Given this list of marker genes TEAD2, ONECUT1, HSF4, PAX1, HOXC6, ZBTB24, RAX2, ZNF611, PRMT5, MSX2, KDM6A, PURG, CENPC, MCM5, ZNF575, ZNF649, SIX6, LITAF, NEUROG1, NKX6-3, ZNF710, TEAD1, TFEC, FEZF1, NHLH1, E2F8 (E2F transcription factor 8), THAP9, CREB3L1, ZFP14, SALL1, ASCL4, ZNF213, YAP1, HES2, ZNF101, ORC5, ZSCAN25, HIF1A, ZNF846, ZNF248, MACROH2A1, ZNF284, TEAD4, ASCL1, SOX3, ZNF789, KDM5B, CUX1, STAT2, RUNX2 (RUNX family transcription factor 2), ZNF66, EZH2, ZNF277, MBD3L5, ZNF329, ZNF483, PROX1, NFAT5, ZNF75CP, MLXIP (MLX interacting protein), ZBTB12, TBX3, SOX8, XBP1, ZNF891, ZNF385D, NFXL1, ETS1, MSC, ZNF16, NLRC5, ZNF80, DLX4, ZNF519, GMEB2, GBX1, SP6, NPAS3, FOSL2, ZNF100, HSPD1, HOXB5, ZNF543, SUB1 (NCBI Gene Id 10923), NFE2L1, BHLHE40 (NCBI Gene Id 8553), HIC2, HSFX3, ATMIN, FOXD4L6 (NCBI Gene Id 653404), ELF1, ZFP3, TBX20, GLI1, HMBOX1, ZNF408, MYB, ATF3, IRF5 (interferon regulatory factor 5), ZNF860, FOXF1, ZNF671, ZNF596, CBFB (NCBI Gene Id 9163), ZNF570, HOXD11 (homeobox D11), HNRNPAB, RUVBL2, PATZ1, ZBTB7C, NRF1, AGO2, REST, PAX7, TFAP2A, ZNF550, KLF5, MBD3L2, CCNT1, HINFP, ZNF362, ZNF146, MXI1, FOXL1, ZNF350, ZSCAN4, ISL1, ZNF420, POU4F1, FOXF2, ESR1, FOXB1, SOX21, NANOG, GLIS2, JMJD4, SIX3, ZBED4, ZNF468, ZNF76, NACC2, NFX1, TERF1, ZNF816, DUXA, TRIM24, THAP10, HOXA2, ZNF875, STAT3, POU1F1, MLXIPL, NR1I3, ARID5B, ZSCAN1, ZNF648, ZNF524, ZNF501, ZIC2, NKX6-2, MED8, PIAS1, KLF13, LIN28B, MIXL1, ZNF696, ZNF658, ZNF829, NR2F6, ZNF480, DACH2, SALL2, OLIG3, NR2E3, RARB, UTY (ubiquitously transcribed tetratricopeptide repeat containing, Y-linked), NLRP3, ZNF675, ZNF263, ZNF212, ASCL3, ZNF404, IRF4, E2F4, TCF24, IKZF4, ZNF630, CREB3, NFYC, MBD4, MYCL, ZBTB39, ZNF735, MAF1 (NCBI Gene Id 84232), ZNF490, ZBTB17, ZIC5, MSX1 (NCBI Gene Id 4487), PLAG1, ZNF438, ZNF621, SMAD5, ZNF607, SP1, ZNF135, ZNF324B, ZNF345, GTF2B, TFAP2B, SOHLH2, ZNF322, ZNF562, ZNF275, DDIT3, HOXA4, TCF7L2, MCM2, HOXB3, ZNF398, THRAP3, RBBP5, HNRNPL, HOXA5, NFE2, ZNF705A, MTA2, TBX10, TEF, TFCP2, ZNF18, GRHL3, TBX21, YBX1, ZNF354A, ZNF280B, ESRRA, ZNF131, HLX, KLF3, ZNF133, ZSCAN31, ZNF792 (zinc finger protein 792), RELB, RXRB, BCL6B, TBX5, ZNF723, FOXP4, ZNF232, ZNF383, BORCS8-MEF2B, SCRT2, CRY2, KLF14, ZNF586, PGR, MYT1L, NPAS4, RXRG, PAX3 (paired box 3), ZNF619, ALX4, ZGPAT, SIM2, ZNF625, ZNF641, FERD3L, RAG2, SLC2A4RG, ARX, FOXO3B, ZNF121, TET1, ZNF341, PER3, ZNF774, EVX1, ZNF680, ATF6B, PPARG, ATOH8, TBPL1, AEBP1, ZNF287, HES4, ZNF561, ZNF92, EBF1, BRF2, ATF2, CREB5 (NCBI Gene Id 9586), PBX4, ZNF597, AR, ZNF563, ZNF772, BSX (brain specific homeobox), DHX33, HSF1, GZF1, MAPT, WDR77, ZNF211, FOXD4L1, PRDM14, TPRX2, ZNF627, ZNF195 (NCBI Gene Id 7748), ZNF701, BNC2, MAEL, ZNF382, GMEB1, PPARA, NKX1-2 (NCBI Gene Id 414257), SCRT1, ZNF160, HES7, ZNF655, ZNF34, CDX4, ZNF878, FOXA3, MBD2, ZNF30, KLF1, JDP2, MSGN1, ELF4, LHX9, BARHL2, ZNF132, ZBTB32, LHX3, TSNAX, XPA, RUNX3, FOXD4L3, ZHX3, NRIP1, PITX1, HDAC5, MECOM, KDM6B, ZNF660, NACC1, ZNF740, PRRX2, KLF2, XRN2, H3-3A (H3.3 histone A), IRX5, BASP1 (NCBI Gene Id 10409), ARNT2, HOXA13, ZNF165, ISL2, HNF1A, TLX3, ZFP42, FOXJ1, ZNF697, NFKBIZ, SREBF2 (sterol regulatory element binding transcription factor 2), ZNF579, ZNF669, BCL6, FOXJ3, ZNF425, TCF3, NFIB, ZNF805, PURB, TLX2, HOXB6, ZNF853, ZNF559, PAX9, TFAP2C, ZNF569, ZNF534, ZNF283, ZNF736, SOX12, USF3, ZNF514, POU5F2, EMX2, UHRF1, RFC1, YBX3, HNRNPU, ZNF134, ZBTB48, SOX9, NKX1-1, ZNF513, ZSCAN5DP, NR6A1, NANOGP1, RAG1, CDX2, MNX1, SP3, MESP2, ZNF439, NOTCH2, VEZF1, ZNF415, ZNF775, IRX3, ISX (intestine specific homeobox), CC2D1A, ZNF572, MEF2B, ZBTB21, DRAP1, RB1, ZNF835, ZNF485, ZNF677, MLX, BPTF, SNAPC1, DHX9, ELL, UBTFL1, ZNF573, ZNF540, HOXC9, KIF2C, ZKSCAN2, AIRE, ZNF799, E2F3, DEAF1, ZBTB8A, FOXA1, ZFP30, PPARD, ST18, ZNF333, SMAD1, NFYA, GSC2, CENPB, LHX4, FOXH1, ZIK1, GATA1, GSC, ZNF37A, SREBF1, NANOGP8, NFKB2, MAZ, CIART, PRDM5, CHTOP, ZNF470, FEZF2, TCFL5, ELK4, PBX2 (PBX homeobox 2), SPI1, ZNF90, PIF1, ZNF143, HES1, TIPARP, ZNF582, POU4F2, ZSCAN26, ZSCAN22, ORC4, FOXI3, DMRTA1, ZNF763, MXD4 (NCBI Gene Id 10608), SIX5, ZNF491, KLF4, HELT, RBBP4, ZFP1, CEBPD, LMX1B, ZNF140, RFX3 (NCBI Gene Id 5991), ZNF580, FOXA2, POLA1, HNRNPA2B1, NHLH2, PPARGC1A, ZFAT (zinc finger and AT-hook domain containing), OSR1, ZBTB22, EHMT2, ZNF417, CREB1 (cAMP responsive element binding protein 1), HOXB9, HOXB13 (NCBI Gene Id 10481), CAMTA2, ADNP, FBXL19, ZNF202, ZNF713, STAT1, ZGLP1, ZSCAN5B, ZNF148, TCF15, PGBD2, H3-3B, FOXO3, INSM1, FLI1, ZNF17, DRGX, TEN1, ZNF793, ETV5, ZBED2, ZBTB26 (NCBI Gene Id 57684), ZNF219, HOXA9, STN1, HNF4A, HES3, SIRT3, NFE2L2 (NCBI Gene Id 4780), ZFP57, TWIST2, UPF3A, TGIF1, UNCX, MBD3L1, CPHXL2, ORC1, KLF9, HDAC4, NR1H3, ZNF440, PDX1, MEN1, ZNF778, RFX6, ZBTB10, ZNF583, KLF16 (NCBI Gene Id 83855), KCNH2, ZNF714, NR4A1, ZFY, BCL11B (BCL11 transcription factor B), ZNF260, GSX2, ZBTB41, ORC2, E4F1, ZNF221, ZNF670, HOXB7, ZNF180, ZNF71, PRDX5, LEUTX, APEX1, NOTO, ZEB1, ZNF367, HOXD10, TSN, KMT2B, BARX1, YY1, ZNF354C, HMX2, PRDM9, ZNF81, GATA5, DBP, RXRA, TWIST1, ZNF416, ZNF888, SRY, NR2F1, ZKSCAN3, HIC1, POU4F3, ZFHX4, ZSCAN20, MGA, ZNF644, SPIC, LONP1, ZNF117, NKX2-5, MITF, ZFP90, TAF7, SOX15, STAT6, ELF2, ZFHX3, NFKB1, MBD3L4, E2F6, PASD1, ZNF689, TERF2IP, NR2F2, IRF3, FOXK2, IRX4, ZNF396, RFX7, DLX2, DMTF1, ZNF184 (zinc finger protein 184), MTA3, ATF7, PGBD1, NSD1 (NCBI Gene Id 6797), RBL1, TAF4, MACROH2A2, POLRMT, TBP, VRTN (NCBI Gene Id 55237), EN2, HSFY1, NR1I2 (NCBI Gene Id 8856), NEUROD4, SP5, CTCFL, ZNF699, NKX3-2, ZNF821 (zinc finger protein 821), ZNF551, KLF7, ZNF746, ZNF479, BARX2, ZNF433, ZNF546, PKNOX1, MYF5, ZNF302, CTC1, ZNF418, DLX1, CEBPE, ZNF777, ZNF276, E2F1, RPS3, CHD3, HNF4G, ZNF182, NKX2-6, ZBTB25, BCL2, NKX2-2, ZFHX2, ZBTB7A, ZNF567, THRB, GOLGB1, ZNF705EP, TOP1, JUND, SOX4, NFATC1, HOXA10, ELF3, ZNF460, MMP12, ZNF189, STK16, SMAD6, HEY2, HSF5, RELA, ZBTB5, ATF1, RREB1, FOXM1, PRDM15, MECP2, POU6F2, FOXP2, CXorf65, GLIS3, ZNF75A, PRDM11, ZNF419, ZBTB37, ACTN4, HES6 (NCBI Gene Id 94875), MEF2A, LEF1 (NCBI Gene Id 51176), ZSCAN12, ARNT (aryl hydrocarbon receptor nuclear translocator), ETV6, SMAD2, PRMT1, ZNF177, ACD, ZNF577, CALCOCO1, ZNF613, RORC, RFX1, HOXC5, MYOD1, PBX1, FOXI2, RFX8, ZFP82, ZNF142, MBD1, TCF7L1, MXD3, HMGB2, POU3F1, MYNN, TBX1, ZNF599, FOXR2, NFE2L3, RAD23B, ANKRD23, RFX2, UBP1, ESRRG, CEBPG, ZKSCAN1, ZNF320, ZNF257, NEUROD1, FOSB, NKRF, ZNF852, TEAD3 (NCBI Gene Id 7005), MEOX2, RBPJL, POU3F3, FOS, ZNF311, PER1, ZBTB49, WBP2, ZSCAN18, HOXA7, NPAS2, HAND1, ZNF674, HOXD12, GRHL2, ZNF692, ATF4, GLI3, ZNF724, EGR4, TBR1, KMT2D, MTA1, BATF2, ZNF454, FOXP1, MAFG, EGR2, MESP1, ZNF14, HNRNPA1, SIRT1, ZBTB1, ZNF444, KLF8, ZNF823, ZNF728, PEG3, IKZF1, AGO1, ZNF442, BMAL1, SIX2, PRDM4, GABPA, FEV, GATA3, ZFX, ZBTB34, NR2E1, E2F2 (E2F transcription factor 2), CEBPA, NCL, MNT (NCBI Gene Id 4335), LHX6, ZBTB20, MTF1, PRDM2, MYBL2, ZNF181, ERG (NCBI Gene Id 2078), FOXC2, JMJD8, ATF6, NFATC3, HOXB4, ZNF566, TFCP2L1, ZNF394, NR4A3, PIH1D1, TERF2, ZNF264, POU2F2, LMNB1, ZBTB14, ZNF737, TP53BP1, GLI4 (NCBI Gene Id 2738), NFIX, TBX6, ZKSCAN5, SOX17 (NCBI Gene Id 64321), ZNF761, REL, ETS2, PITX2, NKX2-8, AHR, ZNF304, FOXS1, ZNF337, SMAD4, HOXD13, MEIS3, NR1H2, MTOR, TFAP2E, ZNF175, MBD3, SKIL, ZNF695, ZNF587B, GLIS1, FOXE1, MLH3, ZNF628, ONECUT3, ZNF471, BRD4, ZNF624, CDC5L, ZNF665, ZNF331, ZNF771, CPSF4, CDC6, MYBL1, KDM2B, TBX19, ZBTB46, HOXA1, BHLHA15, GCM2, ZNF74, NSD2, ZNF892, VSX1, DLX5, IRF6, MAF, FOXO4, ZNF12, YY2, ZSCAN9, ZNF684, POU3F4 (POU class 3 homeobox 4), SIX1, E2F5 (E2F transcription factor 5), ZNF784, ZBED6, OTX1, ANHX, FOXE3, ZNF614, SKI, ASCL2, RBL2, WRN, TP73, TAL1, ARGFX, ZNF492, MEF2D, NTN1, KLF17, BHLHA9, SNAPC3, ZNF571, ZNF616, SATB1 (SATB homeobox 1), ZNF141, SOHLH1 (spermatogenesis and oogenesis specific basic helix-loop-helix 1), NFYB, CSRNP1, ZNF461, DMRT2, ZNF626, SMG6, INSM2, ESR2, ZSCAN29, POT1, NCOA2, ZNF441 (NCBI Gene Id 126068), RPA4, ZNF254, ZNF497, UPF1, ZNF451, ZNF837, LHX1, CREB3L3, MSH2, RERE, SMG7, REPIN1, ZNF766, SPDEF, TFAP2D, ZNF236, MYPOP, TRPS1, NR3C2, RHOXF2, SOX2, SAFB2, NR3C1, NFATC2, CREB3L4, SOX1, BLM, ABL1, ZNF595 (NCBI Gene Id 152687), PBX3, SP8, ZNF280C, RAD50, HEY1, CDK9, HEYL, TFDP3, GATAD2A, FOXD3 (forkhead box D3), MBNL2, SKOR1, MAFK, ZNF169, ZNF718, SLTM, KLF18, OGG1, ZNF75D, ZSCAN2, CREM, MZF1, SMARCB1, EPAS1, TAF9, VENTX, MYOG, PCBP1, NR5A2, CEBPB, ZNF662, ZFP41, HSFX2, BATF, ZNF70, ZNF215, PLAGL1, SP2, TBXT, ZNF876P, VAX1, DMRTC1B, JUN, ZNF280A, BHLHE22, SOX13, FOXR1, FOXO6, TLR9, CREBRF, CTCF, RPA1, ZNF431, DNMT3A, CRY1, RHOXF1, PKNOX2, DPRX, EBF2, BRF1, ZIC1, SMG1, ZNF749, GABPB2, XRCC6, ETV3, CXXC4, MED1, ZNF512B, POU2AF2, STAT4, ZNF808, SOX6 (NCBI Gene Id 84363), RUNX1, ZNF554, ARID4B, ZNF730, NOBOX, ZNF776, HES5 (hes family bHLH transcription factor 5), IRX6, ZBTB2, SOX10 (NCBI Gene Id 8223), FOXO1 (forkhead box O1), RPA2, GRHL1, FOXJ2, ZBTB7B, SUZ12, ZNF354B, ZNF274, ERFL, KDM5A, ELK3 (ETS transcription factor ELK3), BCOR, ZNF32, TBX18, NFIL3, RFX5, LBX1 (ladybird homeobox 1), IRF8, FOXB2 (forkhead box B2), OTP, BRCA1, E2F7, CHD7, HOXC13, FOXN1, IRF1, MTF2, ZNF138, ZNF549, ZNF423, ZNF785, ZNF768, ATOH7, SNAPC4, ATOH1, FOXC1, ENO1, STOX1, ZNF705D, BNC1, CXXC1, HOXC11, ZNF646, ELF5, SHOX2, ZBTB9, RORA (NCBI Gene Id 6095), RFX4, ZNF25, EBF4, MAFB, ZNF732, ZNF253 (NCBI Gene Id 56242), IRX1 (iroquois homeobox 1), ZNF506, DMRT1, TGIF2, ZSCAN23, STAT5A, ZNF517, ARID4A, MEG3, BEND3, SMG5, HIVEP1, FOXD1, DUXB, GRWD1, HMGA1, CBX4, SETX, RBPJ, OLIG2, BAZ2A, SMARCA2, KDM2A, ZSCAN32, ZNF765, SRF, SP9 (Sp9 transcription factor), GTF2A1, LYL1, ZNF623, NKX2-1, ZNF280D, MYBBP1A, ZBTB6, HMX3, ZNF558, SATB2, EEF1D, PHOX2B, HOXC4, OVOL1, ZSCAN5A, ERCC6 (NCBI Gene Id 282965), NFATC4, JPH2, FOXL2, POU3F2, HOXB1 (homeobox B1), ZBTB38, ZNF395, DMRTB1, SNAI3, ZNF610, CREB3L2, ZSCAN10, FOXQ1, ZSCAN16, TBL1X, TBX2, ZNF530, ZNF676 (NCBI Gene Id 163223), ZBED1, IRF2, NOTCH1, BAHD1, HOXA11, MYRFL, ONECUT2, MYF6, DLX3, TAF1C, OLIG1, ERBB4, THAP1, ZKSCAN4, CHCHD2, TCF7, ZNF85, ZNF559-ZNF177, HCFC1, PTF1A, DMRT3, ARID5A, NR1H4, CDC45, ZNF35, CLOCK, PHOX2A, BRD7, KMT2A, SOX5, NKX6-1, TAL2, ZNF705B, CDX1 (caudal type homeobox 1), TLX1, GFI1B, RFXAP, ZNF691, ZNF355P, FOXG1, ZNF19, VAX2 (ventral anterior homeobox 2), CAMTA1, ZNF136, ZSCAN30, GATA2, OTX2, MED12, ASH2L, PAX8, NKX2-4, HSFX1, PAX4, ZNF28, OVOL2, ZBTB45, HDAC6, WIZ, ZNF486, ZNF446, ZNF449 (NCBI Gene Id 353278), UBTF, ZNF174, EHF, IRF9, PURA, ZNF317, ZNF256, TGIF2LY, ZNF430, ZNF114, ZFP92, EVX2, DMBX1, ZNF286A, ESX1, ZSCAN21, DDX11, HOXC10, CUX2, ZNF324 (NCBI Gene Id 64287), ERH, SOX30, SUV39H2, HIVEP2, MTERF3, TFE3, VSX2, ZEB2, ZNF664, PAX2, SMAD9, TP53, ZNF500, ZNF8, SNAI2, SFPQ, ZNF679, ZNF565, TFAM, ZNF77 (zinc finger protein 77), RNF10, ZNF7, THRA, ZIM3, HDAC1 (NCBI Gene Id 3065), ZNF844, ZNF335, RARG, FOXK1, ZFP28, ZNF528, TFDP2, SMARCA4, LHX2, CC2D1B, AHRR, ALX1, GTF2IRD1 (NCBI Gene Id 9569), IRF7, ZC3H8, ZKSCAN8, ZNF716, TFAP4, POU5F1, HOXD8, ALX3, ZNF300, DMRTC1, NKX3-1, ZNF773, ZNF883, ZBTB11, ZNF266, NR1D1, HDX, MUC1 (mucin 1, cell surface associated), PROX2, SOX14, HOXA3, FOXD4, ZNF529, ZFP69B, HIVEP3, CARF, NR2C2, FOXD4L5, HDGF, HSFX4, SOX7, ZNF24, CPHXL, NOTCH4, ZNF316, ZNF93, ZNF69, MAFF, NR2C1, ZNF711, DMRTC2, ZIC4, MBD3L2B, ELL3, NR4A2, SOX11, GABPB1, MEIS1, GLI2, HNF1B, BCL11A, FOXP3, ZNF391, ZBTB33, ZNF205, TET3, HOXD1, JUNB, STAT5B, ZNF764, NPAS1, MAX (NCBI Gene Id 4149), ZNF564, HSFY2 (NCBI Gene Id 92276), ZNF705G, TARDBP, RAX, TERT, DACH1, SNAI1 (snail family transcriptional repressor 1), FOXI1, ZNF343, ZNF700 (NCBI Gene Id 90592), HOXD3, ZNF443 (zinc finger protein 443), KAT7, MEIS2, BACH1, RHOXF2B, CRX, MEOX1, KLF6, TAF1B, ZNF704, BHLHE23, ZNF709, SPIB, NCOA1, SMAD3, HMX1, RBAK, H2AZ1, PRDM16, SP4, ASCL5, ZNF502, EBF3, EN1, HOXA6 (NCBI Gene Id 3203), ETV3L, PAX6, ZNF273, ZNF668, ZNF672, MAFA, MYC, SOX18, SIM1, POU2F1, ZNF536, DNMT1, RBMX, ZNF639, POU6F1, FOXD4L4, GATA6, ZNF3, ZFP2, ZNF557, SAFB, ZNF384, ZNF281, NFIC, SUV39H1, ZNF548, ZKSCAN7, ZNF44, NCOR1, MBD3L3, BARHL1, TINF2, ZNF20, TBX15, ZNF98, DPF1, NPM1, FIGLA, ELL2, CIC (NCBI Gene Id 93977), ZNF880, JPX, ETV7, PRDM1, ELK1, DDN, FOXN2, SIX4, NKX2-3, SARS1, HNRNPD, ZNF23, STOX2, ZNF296, MEF2C, ETV2, ZNF587, ZNF358, ZNF790, VDR, WT1, NR5A1, NFE4, ZNF124, NABP2, LBX2, IKZF3, ZNF250 (zinc finger protein 250), NEUROD2, NFIA, KAT2B, ETV1, LRWD1, TCF4, ZNF681, EGR3, TBX4, MYRF, PROP1, HIF3A, ALKBH2, HOXD9, ZIC3, SHOX, GATA4, NTN3, HMGB1, IKZF2, GSX1, ZNF879 (zinc finger protein 879), ZNF436, ZNF347 (NCBI Gene Id 84671), KCNIP3, ZNF780A, KLF10, ZNF334, ZNF791, ZNF57, CHD2, ETV4, BACH2, CDK5RAP2, HSF2, TAF2 (TATA-box binding protein associated factor 2), CARM1, ZNF750, ZNF366, FOSL1, ZNF620, TSPYL2, ZFP69, ERF, ZNF560, ZNF83, ESRRB, ZNF429, ZNF410, ZNF813, CSRNP3, SMC3, ZNF584, IKZF5, ZNF154, HOXB8, SCX, TCF12, FOXN3, LHX5, ATF5, DUX4, ORC3, ZSCAN5C, EMX1, GBX2, PRRX1, OSR2, BATF3, ZW10, HOXC8, ZNF865, TCF23, ZNF547, ZNF568, ZNF556, SP7 (Sp7 transcription factor, NCBI Gene Id 121340), DMRTA2, XRCC5, ZBTB18, HBP1, ZNF787, ZNF581, HAND2, ZNF682, ZNF667, ZNF10, MYCN (NCBI Gene Id 53360), ZNF683, CSRNP2, TP63, RORB, ZNF217, RRN3, IRX2, PER2, GATAD1, NRL, ZNF282, ZNF397 (zinc finger protein 397), RARA, ZNF578, DLX6, HESX1 (NCBI Gene Id 8820), ZBTB16, RAD21, UBTFL6, TFDP1 (NCBI Gene Id 7027), DHX36, CASZ1, ZNF487, ZNF780B, TAF1 (TATA-box binding protein associated factor 1), POU2F3, ZNF467, KDM1A, HOXD4, MCM10, HMGA2, ZNF286B, ZNF516, BHLHE41, EOMES, MKX, TCF21 (NCBI Gene Id 6943), NR1D2, TBL1XR1, ZNF79, ZBTB4, SMYD3, ZNF239, PAX5, KLF12, NEUROG2, PARTICL, GCM1, ZFP37, TNF, ZNF589, KLF15, THAP11, BBX, MXD1, PARK7, SNCA, BMAL2, ZNF707, PLAGL2, HOXC12, HHEX, TFEB, ZNF527, ZNF496, ZNF555, GFI1, LMX1A, NEUROD6, CXXC5, GTF3C5, OVOL3 (NCBI Gene Id 728361), HOXB2, ZNF251, TBX22, ZNF722, FOXN4, RFXANK, EGR1, HLF, FOXD2, ZNF552, SKOR2, NEUROG3, USF1, PITX3, LRRFIP1, GATAD2B, TGIF2LX, ZNF678, USF2, LHX8, POU5F1B, CCAR1, KLF11, UPF2 (NCBI Gene Id 26019), ZNF426, ZBTB43, ZNF727, ZNF224, TELO2, here is a description of the gene set: species: Homo sapiens Human Gene Set: GOMF_SEQUENCE_SPECIFIC_DNA_BINDING Binding to DNA of a specific nucleotide composition, e.g. GC-rich DNA binding, or with a specific sequence motif or type of DNA e.g. promotor binding or rDNA binding.